Given this list of marker genes Nup214, Nmnat2, Neurod4, Ube2d-ps, Rph3a, Yif1a, Glra1, Tmem179, Mapk8ip2, Map3k14, Fbll1, Mir7b, Lysmd3, Omg, Sox10, Nat8f2, Barhl1, Hdac4, Mthfsd, Gm10863, Fgd4, Creld1, Scrt1, Cyb5r4, Gm13425, Rnu11, Gprin1, Cacng2, Cacng3, here is a description of the gene set: species: Mus musculus Mouse Gene Set: ZFP987_TARGET_GENES from publication Yevshin I, Sharipov R, Kolmykov S, Kondrakhin Y, Kolpakov F (PMID 30445619) Genes containing one or more binding sites for (Zfp987) in their promoter regions (TSS -1000,+100 bp) as identified by GTRD version 20.06 ChIP-seq harmonization.